Given this list of marker genes Rela, Csrp3, Gpi1, Edn1, Ryr2, Chuk, Ankrd1, Nfkb1 (nuclear factor of kappa light polypeptide gene enhancer in B cells 1, p105), Fos, Raf1, Slc9a1 (solute carrier family 9 (sodium/hydrogen exchanger), member 1), Jun, Dmd, Ankrd2, Cav3, Nfkbia, Slc8a1, Ankrd23, Ttn, Tcap, Mapk14, Pik3ca, Gsn, Ddr2, here is a description of the gene set: Any process that results in a change in state or activity of a cell or an organism (in terms of movement, secretion, enzyme production, gene expression, etc.) as a result of a myofibril being extended beyond its slack length. species: Mus musculus Mouse Gene Set: GOBP_RESPONSE_TO_MUSCLE_STRETCH